Given this list of marker genes RNA5SP336, ENSG00000254443, CHID1, CD151, ARFIP2, CTSD, MIR6744, NAV2-AS5, CARS1-AS1, OR51H2P, MUC5B, PRMT3, PIDD1, OR52A4P, OR52Z1P, PNPLA2, INS-IGF2, GALNT18, RASSF10-DT, GVINP2, SMPD1, RNU7-49P, IGSF22, DENND2B, RPL34P24, CD81, KRTAP5-4, SNORA62, LINC01150, IFITM1, MRGPRE, KRTAP5-2, MIR7847 (NCBI Gene Id 102465993), OR52N4, KRTAP5-AS1, OR10A5, SBF2, MRGPRX1, MRGPRG, ENSG00000282556, NRIP3, IFITM5, COX8BP, LINC02989, MUC6, TSSC4, PKP3, RNA5SP337, GTF2H1, OR52J1P, RN7SKP90, OVCH2, KRT8P41, RNU1-91P, RNA5SP332, OR52Q1P, UEVLD, SOX6, MRGPRX7P, TUB-AS1, FAR1, HTATIP2, SRSF3P1, RNU7-50P, OR2D2, OR51E2, MRGPRX12P, OR51B6, OR51B5, OR2D3, NLRP10, OR51A3P, RPLP2, RNA5SP335, RNA5SP330, TPP1, DCHS1-AS1, ART1 (ADP-ribosyltransferase 1), OR52H2P, HBBP1, TRIM68, OTOG, MIR4686, SNORA3A, OR10A6, RNU6-943P, OR56A1, RNA5SP334, RRM1, OLFM5P, OR51A2, GATD1-DT, DRD4, RNF141, HBB, MIR5691, UBQLN3, ENSG00000255476, RNA5SP333, ENSG00000304743, HIGD1AP5, OR51G2, PRR33, OR51F2, POLR2L, LINC01219, OR10A3, COX6CP5, TNNT3, LINC02682, ENSG00000238387, CENPUP1, RPL7AP55, MIR6743, TSG101, TMEM41B, MIR4687, COX6CP18, ENSG00000293242, PDE3B, OR52J3, NAV2-AS2, CEND1, HRAS, SIGIRR, TMEM9B, OR56B1, PHRF1, TRPC2, PANO1, OR52K2, ENPP7P15, TRIM5, OR52H1, IFITM2, OR4F2P, PRADX, MRGPRX3, OR52P2P, TOLLIP, ADM, OSBPL5, OR51A7, OR52J2P, CASC23, OR52B4, OR52B3P, RDXP1, PLEKHA7, OR51Q1, OR7E12P, HBE1, SSU72P6, OR52N2, OR51D1, TNNI2, FAM99A, H3P33, OR51S1, OR7E14P, MUC5AC, APBB1, SLC22A18 (solute carrier family 22 member 18), FAR1-IT1, MRGPRX11P, MIR483, STIM1, NAV2, GVINP1, OR51A8P, MRPL17 (NCBI Gene Id 64996), NAV2-AS4, MRGPRG-AS1, TMEM9B-AS1, OR52U1P, BRSK2, DBX1, RPS13, LMNTD2, GATD1, H19, UBQLNL, RRM1-AS1, OR52E3P, CSRP3, RPL26P30, LINC00958, CALCP, SAA3P, KCNJ11, NCR3LG1, ASCL3, MIR4486, OR51A10P, OR52M2P, SCUBE2, TAF10, TSSC2 (tumor suppressing subtransferable candidate 2 (pseudogene)), DENND2B-AS1, EIF4G2, MRGPRX8P, NLRP14, TRIM6, OR52E2, OR51A9P, CHRNA10, YWHABP2, RASSF10, KCNQ1, SNORD14B, MICAL2 (NCBI Gene Id 9645), MRGPRX2, KRT8P49, TRPM5, MIR4298, OR5P1P, EPS8L2, MISFA, RN7SL188P, OR56B2P, FAM86GP, ENSG00000290098, OR52M1, MIR302E, IGF2, OR52R1, CRACR2B, MTND5P21, ANO9, MIR6073 (NCBI Gene Id 102464826), CICP23, OR5P3, NELL1, STIM1-AS1, CDHR5, LINC02548, CALCB (calcitonin related polypeptide beta), OR52N1, PSMA1, OR52K3P, SPON1, RPL21P94, OR51L1, OR52A5, KCNQ1-AS1, SSU72L4, SYT9, SDHCP4, MUC5B-AS1, OR7E41P, SAAL1, LINC02752, STK33, CSNK2A3, OR52D1, ZDHHC13 (zinc finger DHHC-type palmitoyltransferase 13), RNH1, OR52V1P, OR7E117P, OR52I2, LEISA1, RRP8, TRIM21, OR51F5P, AMPD3, SWAP70, NUCB2, ENSG00000301396, OR5E1P, ADM-DT, HNRNPA1P53, KCNQ1DN, TALDO1, OR52E5, CARS1, COPB1, TRIM22, OR51B4, SNRPCP5, TMEM80, RHOG, MRGPRX6P, SAA2-SAA4, E2F8, LDHAL6A, OR5P2, OR52Y1P, NUP98, LRRC56, RNA5SP329, AP2A2, OR51F3P, OR5P4P, OR52N3P, OR51C4P, ZNF143, ENSG00000252778, RPL23AP65, ENSG00000207407, TRIM34, CAVIN3, OR51P1P, PGAP2, SSU72L1, OR6A2, OR52I1, MIR675, IRF7, SLC25A22, HBD, SAA4, AKIP1, OR52X1P, FAM99B, OR10A2 (olfactory receptor family 10 subfamily A member 2), MUC2, OR52P1, CDKN1C, FHIP1B, ENSG00000308330, C11orf58, OR51A4, MIR6124, OR51K1P, MRGPRX4, TEAD1, ENSG00000287935, SNORA52, RIC3, TUB, DCHS1, OR51A1P, NDUFA5P8, OR51E1, MIR4299, SPON1-AS1, RN7SL838P (RNA, 7SL, cytoplasmic 838, pseudogene), SPTY2D1, IGSF22-AS1, OR10AB1P, RNU6-447P, OR56A7P, C11orf16, ZNF215, SERGEF, BGLT3, OR51B2, MIR8070, AKR1B1P3, TRIM3, ZBED5-AS1, RNA5SP331, MRGPRX10P, OR52B6, RPL39P26, SNORD97, KRTAP5-5, CCKBR, OR52W1, PSMD13, HPS5, BTBD10, TRIM66, OR56B3P, INS, MRGPRX9P, WBP1LP10, ENSG00000246308, CD81-AS1 (NCBI Gene Id 101927682), DNHD1, KRTAP5-1 (keratin associated protein 5-1), PHLDA2, OR56A5, DKK3, OR52E7P, OR51A5P, IFITM10, TH, KCNC1, OR52T1P, OR52E6, RNU6ATAC33P, OR51T1, OR52N5, TMEM86A, NAV2-AS3, HBG1, PTDSS2, LDHC, IPO7, KCNQ1OT1, RN7SKP151, RPS29P20, OR51B3P, RPL29P21, LMO1, PTH, OR52K1, LYVE1, RPL21P97, RIC8A, OR51J1, NRIP3-DT, IRAG1, PPFIBP2, MOB2, TSPAN4, LINC02751, USP47, MRPL23, SAA1, MIR4694, RPS3AP39, OR52B1P, C11orf42, LDHA, SSU72L2, SSU72L5, MIR210, OR51AB1P, MIR210HG, OR55B1P, ILK, C11orf40, ENSG00000255367, OR51V1, CSRP3-AS1, OR51M1, OR52L1, ENSG00000289997, BET1L, OR52A1, PCNAP4, DUSP8, OR52L2P, SSU72L3, LINC02689 (long intergenic non-protein coding RNA 2689), OR51C1P, PPIAP40, INSC, OR56A4, ZNF143-AS1 (NCBI Gene Id 651375), OR52S1P (NCBI Gene Id 79521), PIK3C2A, OR51F1, OR2AG1 (olfactory receptor family 2 subfamily AG member 1), LINC02729, LINC01001, RPL36AP39, ST13P5, OR51G1, TMEM258P1, B4GALNT4, SCT, LINC02749, LINC02683, SAA2, LINC02708, MORF4L1P3, MTCH1P2, HMGN2P36, OLFML1, USH1C, RNU6-593P, MRGPRX5P, RRAS2, IFITM3 (NCBI Gene Id 10410), RIC3-DT, OR56A3, LINC02547, RASSF7, PGGHG, CYB5R2, HMGB1P40, OR52E1, DENND5A, RNU6-878P, OR10A4, LINC02709, OR52B5P, CTR9, OR56B4, OR51A6P, ABCC8, ENSG00000254951, SYT9-AS1, TRIM6-TRIM34, RPS24P14, NDUFA5P1, RNU6-1143P, RNU7-28P, SBF2-AS1, ART5, RN7SKP50, OR51B8P, SIRT3, ENSG00000251661, ZNF214, LMNTD2-AS1, NAV2-AS1, MIR4485, TPH1, IGF2-AS, NAV2-IT1, OR51N1P, MMP26, C11orf21, CYP2R1, ANO5, SNORA3B, KRTAP5-6, KRT18P58, WEE1, GLTPP1, OR52E8, OR51R1P, SCGB1C1, TOLLIP-DT, PTPN5, DEAF1, OR52B2, OR2AG2, ENSG00000255167, XNDC1CP, PRR13P2, OR51H1, SNORA23, SNORD14A, OR52E4, OR51F4P, SYT8, CIMAP1A, ENSG00000255462, PARVA (parvin alpha), ZNF195, KRTAP5-3, ASCL2, OR51I1, MIR3159, HNRNPA1P76, NLRP6, EIF3F, MRGPRX13P, CNGA4, RNU6-1025P, TSPAN32, SNORA54, LINC02545, NAP1L4, SLC22A18AS, TIMM10B (translocase of inner mitochondrial membrane 10B), MYOD1, CALCA, MRPL23-AS1, RPL27A, HPX, SLC6A5, IRAG1-AS1, BMAL1, LINC02688, HBG2, LSP1, RPL36AP37, ZBED5 (zinc finger BED-type containing 5), VPS51P5, SLC25A51P4, OR51I2, RBMXL2, here is a description of the gene set: Human Gene Set: chr11p15 species: Homo sapiens